The following is a description of a gene set: NOD2 is an intracellular receptor for the bacterial cell wall component muramyl dipeptide (MDP) and variants of NOD2 are associated with chronic inflammatory diseases of barrier organs e.g. Crohn disease, asthma and atopic eczema. It is known that activation of NOD2 induces a variety of inflammatory and antibacterial factors. The exact transcriptomal signatures that define the cellular programs downstream of NOD2 activation and the influence of the Crohn-associated variant L1007fsinsC are yet to be defined. To describe the MDP-induced activation program, we analyzed the transcriptomal reactions of isogenic HEK293 cells expressing NOD2wt or NOD2L1007fsinsC to stimulation with MDP. Importantly, a clear loss-of-function could be observed in the cells carrying the Crohn-associated variant L1007fsinsC, while the NOD2wt cells showed differential regulation of growth factors, chemokines and several antagonists of NF-κB, e.g. TNFAIP3 (A20) and IER3. Human Gene Set: GSE22611_UNSTIM_VS_6H_MDP_STIM_NOD2_TRANSDUCED_HEK293T_CELL_DN from publication Billmann-Born S, Till A, Arlt A, Lipinski S, Sina C, Latiano A, Annese V, Häsler R, Kerick M, Manke T, Seegert D, Hanidu A, Schäfer H, van Heel D, Li J, Schreiber S, Rosenstiel P (PMID 21335489) studied in species Homo sapiens Genes down-regulated in HEK293 cells over-expressing wildtype NOD2: untreated versus muramyl dipeptide for 6h., and this is the list of marker genes: ZC2HC1A, HNRNPA0, PAOX, RHAG, CSTB, ATPAF2, CES3, CROCC, TASP1, NAV2, PHF10, SRC, PLCH1, SYCP2, WHRN, SOCS3, MAFF, CAPG, RTF1, INSIG1, SLC29A3, SLAMF7, ORM1, EPB41L3, CCRL2, CASP1, SETBP1, SCAPER, TTLL4, CD40, LRRC17, SAYSD1, IFNA5, SPHK1, CD44, FCGR2C, UROD, PPIP5K2, OSBPL3, LRRC14, ACE2, C11orf21, PTPA, BRD3, XCL1 (NCBI Gene Id 92337), SLC11A2, RAB11FIP2, SLC43A3, OVGP1, RANGAP1, PLCL2, AK4 (adenylate kinase 4), NPY1R, CLCN5, RAB1A, EIF5A, TRMT13, MED12, RABL3, EIF5, DGKA, MMP1, ADAM17, CCR1, PRKACA, RIPK2, SQSTM1, TPP1, RBMXL2 (RBMX like 2), CIR1, MMP14, NDUFB2, MYH14, ALB, RRP1, RCBTB2, REXO2, GREB1, CRH, GNPDA1, PLPP3, TMEM151B, PRUNE2, ATP2B1, VAC14, NFIX, ZNF107, GPRC5B, CETN3, ZXDC, NUBP2, IDH1, ZNF573, KLF9, NOL3, MRPL11, RPS24, ECHS1, NDUFAF4, HDAC7, SLC7A11, PRX, CD48, CYBC1, SLC2A3, CZIB, TCP10L, FGF8, SLC34A1, CRYZL1, PLAA, PPP1R15A, CCNE2, TRPM6, LPAR6, SCG5, PLA2G1B, MRPS30, MEX3C, CCL20, BTG3, EVL (NCBI Gene Id 51466), ZCCHC4, CSN3, PON3 (paraoxonase 3), PYGL, ACKR4, PMCHL1, ITPR1, ATR, ATP13A3, RABGAP1L, PDE4DIP, HHLA2, CCL18, EZH1, UBA5, PHLDB1, DZIP1, MCM3, THAP3, PCDHGA9, MRNIP, DCUN1D4, IGLV1-44 (NCBI Gene Id 28823), DLGAP4, ORC4, MBD3, EBI3, GAK, EXOSC10, SMG7-AS1, TRIO, ERCC8, NT5E, ALDH1L1, SLC27A3, ENSG00000291006, NSMCE4A, KAZALD1, PF4, IL36G, SH3BP5, EFEMP2, IFNAR1, EDN1, P2RX7, GRIK4, SLC7A1, STN1, MTR, ZNF721, MINDY2 (NCBI Gene Id 54629), XYLT2, LMTK2, NCR1, TRIP10, SZRD1, SNRPF, GATC, IPCEF1, SIM1, CD68 (CD68 molecule), KRT13, LAMP1, TIMP2, CMAS, IDH3B, APPL2, GCNT4, UBE3B, GTF2E1, PLD1, IL13RA1, MRPL40, DHX34, DUSP10, USP48